Given this list of marker genes Mfhas1, Cd300ld, Dapl1, Psors1c2, Asah1, Krt86, Nlrp1a, Sema3e, A2m, Ifi211, Zfp398, Ackr3, Cyp4f18, Ms4a14, Nudt16, Evi2, Naip2, Atg9b, Cyp4f39, Ifi213, Meis2, H2-Eb2, Tnfsf18, Chd9, Zfp52, Micu3, Stxbp1, Bbox1, Apol7e, Trim34a, Msantd1 (Myb/SANT-like DNA-binding domain containing 1), Alox12e (arachidonate lipoxygenase, epidermal), Ankib1, Slc9a4, Trim5, Capns2, Mill2, Ccdc73, Rp9 (retinitis pigmentosa 9 (human)), B3gnt3, Adam19, Abraxas1, Zfp992, Thap2, Nos2, Rab32, Gp1bb, Cldn34c1, Upk3bl (uroplakin 3B-like), Gsdma, Prl2c2, Ahnak2, Zfp456, Epsti1, Btnl2, Serpinb1a, Krt36 (keratin 36), Serpinb7, Daglb, Ndrg4, Spink5, Hoxc11, Lvrn, Crct1, Parp3, Apol7c, Fyb1, Sprr2a2, Hmgn5, Rwdd4a, Npas2, Lyrm4, Slc4a4, Snx24, Dmrt2, Tchh, Clec2g, Pglyrp4, Gapt, Slco5a1, Casp12, Klk7, Snx10, Slamf1, Lacc1, Slamf7, Paqr8, Mgat3, Fa2h, Mblac2, Resf1, Bhlhe22 (NCBI Gene Id 59058), Phf24, Cst6, Efhb, Ccl1, Aldh3b3, Ubd, Insrr, Ace2, Naip5, Klra4, Ly6m, Lrrk1, Cldn18, Gbp6, Plekhg3, Diaph2, Prr9, Cluh, Mmrn1, Tppp3, Hephl1, Qpct, Serpinb12, Foxn1, Trim12a, Slurp1, Alox12b, Idi2, Dusp23, Rasa1, Zfp804a, Anxa2, Ido1, Arg1, Paqr4, Pou3f1, Naip6, Heatr5a, Tnxb, Nim1k, Prmt5, Batf2, Tspan32, Dtx3l, Gvin1, Pgm2, Flrt3, Adgrf4, Pcolce, Zdhhc4, Klra8, Ubash3b, Pop4, Prl2c3, Cep41 (NCBI Gene Id 83922), Spag17, Slc6a20a, Sprr1a, Pdxdc1, Gpatch1, Plcxd2, Coch, Samd9l, Rab27b, Aoah, Cd200r2, Nol7, Krtdap, Ackr2, Elovl4, Ndufa12, Mmp28, Iars2, Zfp683, Chst4, Akap13, Hspa4l, Coq2, Scg3, Zfp101, Flacc1, Rbp2 (NCBI Gene Id 19660), Ccdc59, Nxpe2, Calml4, Cpa4, Ccdc122, Jakmip1, Sirpb1c, Lpcat2, Il18, Ang, Vmn2r96, Trim30d, Fbxo4, Adgrg7, Cd244a, Ly6g6c, Nccrp1, Lipm, Duxbl1, Ptk6, Tdrd9, Irf1, Gstp3, Klra6, Ccdc34, Idnk, here is a description of the gene set: studied in species Mus musculus from publication Zeng Z, Gu SS, Wong CJ, Yang L, Ouardaoui N, Li D, Zhang W, Brown M, Liu XS (PMID 36240281) Mouse Gene Set: ZENG_GU_ICB_CONTROL_METAGENE_19_PRECICTIVE_ICB_RESPONSE Most patients with cancer are refractory to immune checkpoint blockade (ICB) therapy, and proper patient stratification remains an open question. Primary patient data suffer from high heterogeneity, low accessibility, and lack of proper controls. In contrast, syngeneic mouse tumor models enable controlled experiments with ICB treatments. Using transcriptomic and experimental variables from >700 ICB-treated/control syngeneic mouse tumors, developed a machine learning framework to model tumor immunity and identify factors influencing ICB response. Projected on human immunotherapy trial data, found that the model can predict clinical ICB response. further applied the model to predicting ICB-responsive/resistant cancer types in The Cancer Genome Atlas, which agreed well with existing clinical reports. Metagene_19 is highly enriched in acute myeloid leukemia (LAML), which is highly responsive to anti-PD1, and depleted in GBM (table S10), a cancer type that is resistant to anti-PD1 (37, 44). Pathway enrichment using the top genes in metagene_19 (table S5) showed regulation of the inflammatory response and myeloid cell differentiation. Top-ranked genes in this metagene include Trim12a and Trim5, which encode ubiquitin E3 ligases involved in autophagy